Given this list of marker genes PIK3CA, ADCY2, GNG13, GNB5, GNAQ, CTNNB1, PRKACA, TLN1, GNB2, GNG5, ADM, GNG7, GNG8, PANX1, ADCY4, PIK3CB, ADCY1, ADCY6, PDPK1, GNG12, ADCY8, VCL, PRKAR2B, PECAM1, ADCY9, GNB4, GNB1, MLST8, GNG4, KDR, GNG2 (NCBI Gene Id 54331), PRKACB, GNB3, PIK3R2, GNG11, GNG3, MTOR, MAPKAP1, MMP14, GNG10, CAPNS1, AKT1 (AKT serine/threonine kinase 1), FLT4, ADCY3, PRKACG, PIK3CD (NCBI Gene Id 5293), GNAS, CDH5, TRPV4, CALM1, NOS3, PRKAR2A, PRR5, PIEZO1, GNGT1, CALCRL, PKN2, CAPN2, ADCY5, ADCY7, GNGT2, RAMP2, GNA11 (NCBI Gene Id 93626), P2RY2, CAPNS2, PRKAR1A, RICTOR, FYN, PRKAR1B, here is a description of the gene set: part of: Response of endothelial cells to shear stress species: Homo sapiens Laminar shear stress produced by high fluid flow across endothelial cells causes the cells to produce vasodilatory nitric oxide (NO) and to elongate from polygonal to ellipsoid such that their long axes become parallel with direction of the flow. Nitric oxide produced by endothelial cells modulates soluble guanylyl cyclase and cGMP-dependent kinase in surrounding smooth muscle cells to cause vasodilation. By optimizing blood flow without inflammation, the response to laminar shear stress is atheroprotective.<br>Laminar shear stress on endothelial cells is detected by the glycocalyx, caveolae, cilia, the mechanosensitive ion channel PIEZO1 located on the apex of the cell, and the PECAM1:CDH5:KDR (PECAM1:VE-cadherin:VEGFR2) complex located on the lateral surfaces between adjacent cells. The active molecular components, mechanisms of activation, and downstream events related to the glycocalyx, caveolae, and cilia are incompletely characterized so the annotation here focuses more on PIEZO1 and the PECAM1:CDH5:KDR complex.<br>The force of the flow on the membrane of the endothelial cell activates the mechanosensitive ion channel PIEZO1 and, indirectly, the ion channel TRPV4 to transport cations, notably calcium, from the extracellular region to the cytosol. Cytosolic calcium activates the protease complex Calpain2 to cleave the cytoskeletal proteins TALIN1 and VINCULIN, resulting in changes to the cytoskeleton that alter the shape of the endothelial cell.<br>Flow-sensitive potassium channels (which may include Kir2.1 and TREK1) and chloride channels (which may include LRRC8A) are also observed to open, however their mechanisms of activation and downstream events are incompletely characterized.<br>Cytosolic calcium activates Pannexin channels to release ATP, which binds the P2RY2 (P2Y2) receptor on the cell surface in an autocrine and paracrine manner and thereby activates Galpha(q/11)-PI3K-AKT1 signaling. Both signaling by P2RY2 and signaling by a mechanosensitive complex containing PECAM1 and KDR (VEGFR2) (inferred from mouse homologs in Tzima et al. 2005) produce phosphatidylinositol 3,4,5-trisphosphate (PIP3), which binds AKT1 and enhances the phosphorylation of AKT1 on serine-475 by the mTORC2 complex.<br>Through a PI3K-independent mechanism, P2RY2 signaling and cytosolic calcium activate the kinase PDPK1, which phosphorylates the kinase PKN2 (PRK2). Phospho-PKN2 then phosphorylates AKT1 on threonine-308. Phospho-T308,S475-AKT1 phosphorylates serine-1177 of NOS3 (eNOS) while phospho-PKN2 also phosphorylates serine-1179 of NOS3, causing increased nitric oxide production.<br>Laminar shear stress increases secretion of Adrenomedullin (ADM), a vasodilator, by endothelial cells through an uncharacterized mechanism. ADM binds the AM1 receptor and signals through G-alpha(s), adenylate cyclase, and resultant cAMP to activate protein kinase A (PKA) to phosphorylate serine-633 of NOS3, further increasing nitric oxide production.<br>The sphingosine 1-phosphate receptor S1PR1, which couples to Galpha(i1) and Galpha(i3), contributes in a ligand-independent manner to activation of AKT and NOS3, however the intermediate steps are incompletely characterized. Other GPCRs such as GPR68 also become activated, possibly through flow-induced deformation of the extracellular domain. Reactome Pathway: High laminar flow shear stress activates signaling by PIEZO1 and PECAM1:CDH5:KDR in endothelial cells